Given this list of marker genes Wnt10b, Snai2, Mecom, Prl2c3, Cebpa, Eif2ak2, Kitl, Pim1, Wnt1, N4bp2l2, Atxn1l, Wnt5a, Irgm1, Thpo, Tsc22d1, Ace, Cxcl1, Pdcd2, Kat7, here is a description of the gene set: Mouse Gene Set: GOBP_REGULATION_OF_HEMATOPOIETIC_STEM_CELL_PROLIFERATION species: Mus musculus Any process that modulates the frequency, rate or extent of hematopoietic stem cell proliferation.